The following is a description of a gene set: Biomarkers for urea cycle disorders Human Gene Set: WP_BIOMARKERS_FOR_UREA_CYCLE_DISORDERS species: Homo sapiens, and this is the list of marker genes: GPT, ARG1, NAGS, GATM, GOT1, F10, OTC, GLS2, GAMT, ASS1, F7, ASL